Given this list of marker genes YWHAG (NCBI Gene Id 96443), HSPD1, HLA-DRB3, KLHL22, PDCD1, PRKAA1, USP5, FBXO38 (NCBI Gene Id 81545), MR1, HMGB1, AHR, UFL1, CD274, MAPK3, HLA-A, IL4I1, SLC22A13, HLA-DRB1, here is a description of the gene set: Human Gene Set: GOBP_T_CELL_MEDIATED_IMMUNE_RESPONSE_TO_TUMOR_CELL studied in species Homo sapiens An immune response mediated by a T cell triggered in response to the presence of a tumor cell.